The following is a description of a gene set: species: Mus musculus Mouse Gene Set: GOBP_PERICARDIUM_DEVELOPMENT The process whose specific outcome is the progression of the pericardium over time, from its formation to the mature structure. The pericardium is a double-walled sac that contains the heart and the roots of the aorta, vena cava and the pulmonary artery., and this is the list of marker genes: Vcam1, Bmp7, Itga4, Pdpn, Heg1 (heart development protein with EGF-like domains 1), Lrp6 (NCBI Gene Id 77387), Rxra, Smad3 (SMAD family member 3), Rpgrip1l, Setd2, Sos1, Mecom, Ccm2, Tbx20, Dll4, Epo, Epor, Bmp5, Bmp2 (bone morphogenetic protein 2), Wnt5a, Wt1, Notch1, Smad2 (NCBI Gene Id 319898), Nkx2-6, Tgfbr3, Tbx5, Flrt3, Hand2